The following is a description of a gene set: Biallelic loss-of-function mutations in <i>PALB2</i> results in Fanconi anemia subtype N (FA-N), which is phenotypically very similar to Fanconi anemia subtype D1, caused by biallelic loss-of-function of <i>BRCA2</i>. FA-D1 and FA-N are characterized by developmental abnormalities, bone marrow failure and childhood cancer susceptibility, especially childhood solid tumors, such as Wilms tumor and medulloblastoma. Monoallelic <i>PALB2</i> loss-of-function is an underlying cause of hereditary breast cancer in particular, but inactivating <i>PALB2</i> mutations are also to a lesser extent found in some other cancer types, including pancreatic cancer. Germline <i>PALB2</i> mutations are somewhat less frequent than those occurring in <i>BRCA1</i> and <i>BRCA2</i>, but cause a comparably high risk of developing breast cancer. Therefore, <i>PALB2</i> is a high-risk breast cancer predisposing gene.<br><br>PALB2 interacts with both BRCA1 and BRCA2, and serves as a bridge that connects BRCA2 with BRCA1 at sites of DNA double-strand break repair (DSBR). PALB2 also interacts directly with DNA and takes part in the regulation of RAD51-mediated homologous recombination. PALB2 loss-of-function mutations can affect its interaction with BRCA1 when they affect the N-terminal coiled-coil domain that is necessary for BRCA1 binding. Mutations in the coiled-coil domain can also affect PALB2 self-interaction, recruitment to double-strand break sites, homologous recombination repair and RAD51 foci formation. PALB2 missense mutants that do not bind to BRCA1 can still be recruited to DSBR sites, probably through interaction with other proteins involved in DSBR, but they are unable to restore efficient gene conversion in PALB2-deficient cells and they render cells hypersensitive to the DNA damaging agent mitomycin C, with some variants also presenting sensitivity to PARP inhibitors.<br><br>Mutations evaluated so far in the central region of PALB2, which contains the ChAM motif and the MRG15-binding region, have shown no functional impact on the protein.<br><br>Mutations affecting the C-terminal WD40 domain of PALB2 impair its ability to interact with BRCA2, RAD51 and/or RAD51C. In addition, disruption of the WD40 domain can lead to the exposure of a nuclear export signal (NES), leading to cytoplasmic translocation of PALB2. Mutations affecting the C-terminal domain of PALB2 are more frequent than mutations that affect the N-terminus and have been observed, as germline mutations, in familial breast cancer and in Fanconi anemia, but somatic mutations also occur in sporadic cancers. Cells that express PALB2 mutants defective in BRCA2, RAD51 and/or RAD51C binding show reduced ability to perform DSBR via homologous recombination repair, form fewer RAD51 foci at DSBR sites, and are sensitive to DNA crosslinking agents such as mitomycin C.<br><br>For review, please refer to Tischkowitz and Xia 2010, Pauty et al. 2014, Park et al. 2014, Nepomuceno et al. 2017, Ducy et al. 2019, Wu et al. 2020, Nepomuceno et al. 2021. part of: Diseases of DNA Double-Strand Break Repair studied in species Homo sapiens Reactome Pathway: Defective homologous recombination repair (HRR) due to PALB2 loss of function, and this is the list of marker genes: RAD51D, ATM, NBN, BLM, SEM1, RAD50, BARD1 (NCBI Gene Id 580), EXO1, XRCC2, RBBP8, RMI2, RAD51C, RAD51, KAT5, TOP3A, RAD51AP1, BRCA1, DNA2, RMI1, MRE11, WRN (NCBI Gene Id 7486), BRIP1, PALB2, BRCA2, RAD51B